Given this list of marker genes PDE5A, MROH7, PCDHAC2, THRB, PCDHA2, NAV3, GLRA2, KRIT1, MYT1, SLC22A23, PRMT8, BLCAP, ZFHX4, SMAD2, RALA, H3-3B, RNF38 (ring finger protein 38), PCDHA3, PRP4K, NRBF2, PCDHA4, TPBG, TMED9, ESRRG, PRR30, CELF6, DNM3, AHNAK, ERI3, PCGF5, PCDHA1, GGA1, STC2, NUFIP2, DPYSL3, EIF4G1, NRG1, BCL9, EGFLAM, PRKACB, MYCL, SLF2, SLC25A3, CCDC28A, IRF2BPL, ARID5B, FOSB, BMPR2, PHF21A, ERC2, ADRA2B, NFASC (neurofascin), SRGAP3, RXRG, NAA15, CLDND1, ZBTB18, ALKBH8, KCTD11, IL6ST, RTL5 (NCBI Gene Id 340526), KLHL2, CLSTN1, HIPK1, ARK2C, N4BP3, PAM, DAPK1 (death associated protein kinase 1), PRR7 (NCBI Gene Id 80758), PCDHA12, WAPL, ZNF655 (zinc finger protein 655), ATXN1, PCDHA13, CSNK1G3, BCL7A, RBPMS, PTBP2, SUGP2, TARDBP, PCDHAC1, PCDHA11, WDFY1, PAX2, MARK2, FXR2, PCDHA7, SUGP1, PALM2AKAP2, DLGAP4, CRMP1 (NCBI Gene Id 1400), PCDHA8, TNRC6B, SLC39A10, KLF12, PCDHA10, CADM1, CNOT6, PDE4D, PCDHA5, SRSF4 (serine and arginine rich splicing factor 4), LARP4B (La ribonucleoprotein 4B), PCDHA9, PCDHA6, KDM5C, CLTB, FAM219A, ZDHHC5, TOB2, MEF2C, OLA1, here is a description of the gene set: Genes having at least one occurence of the motif GGTGTGT in their 3' untranslated region. The motif represents putative target (that is, seed match) of human mature miRNA hsa-miR-329 (v7.1 miRBase). Human Gene Set: GGTGTGT_MIR329 studied in species Homo sapiens